Given this list of marker genes Xpo5, Bcdin3d (BCDIN3 domain containing), Tarbp2, Dicer1, Lin28a, Trub1, Prkra, Dhx36, Ran, Carlr, here is a description of the gene set: studied in species Mus musculus Binding to a precursor microRNA (pre-miRNA) transcript, a stem-loop-containing precursor of microRNA. Mouse Gene Set: GOMF_PRE_MIRNA_BINDING